Given this list of marker genes B2M, HLA-A, HLA-C, HLA-B, HLA-F, HLA-E, HLA-G, here is a description of the gene set: Human Gene Set: KEGG_MEDICUS_PATHOGEN_HTLV_1_P12_TO_ANTIGEN_PROCESSING_AND_PRESENTATION_BY_MHC_CLASS_I_MOLECULES Pathway Definition from KEGG: P12 -| (MHCI+B2M) HTLV-1 p12 to antigen processing and presentation by MHC class I molecules. Pathway ID: N00492. Pathway type: Pathogen. Pathway class: nt06229 MHC presentation. studied in species Homo sapiens